The following is a description of a gene set: studied in species Homo sapiens Endochondral ossification with skeletal dysplasias Human Gene Set: WP_ENDOCHONDRAL_OSSIFICATION_WITH_SKELETAL_DYSPLASIAS, and this is the list of marker genes: KIF3A, SLC38A2, IGF2, GHR, ADAMTS5, VEGFA, CDKN1C, FRZB (NCBI Gene Id 2487), SERPINH1, PLAT, PTH1R (parathyroid hormone 1 receptor), IHH, IFT88, PTHLH, SOX9, GH1, SCIN (NCBI Gene Id 85477), AKT1, FGF18, CALM1, SPP1, BMP6, HDAC4, STAT1, COL10A1, TGFB2, CHST11, SOX5, IGF1R, IGF1, SOX6, RUNX2, MEF2C, COL2A1, GLI3, PTCH1, DDR2, NKX3-2, BMPR1A, BMP7, STAT5B, ACAN, TIMP3, FGF2 (fibroblast growth factor 2), CTSV, ADAMTS4, MMP13, MGP, RUNX3 (RUNX family transcription factor 3), TGFB1, ADAMTS1, ALPL, THRA, MMP9, PTH, CST5 (NCBI Gene Id 1473), FGFR1, CAB39, FGFR3, HMGCS1, PLAU, PRKACA, ENPP1